Given this list of marker genes HCRTR1, MIA, FOXD3-AS1, AZGP1, PLAC9P1, GPR83, COL20A1, ST3GAL6-AS1, POLR3G, LINC02024, MPZ, GJC3, CDH19, SHC4, TFAP2A, OLFML2A, ARHGEF26, PLP1, PCDH20, MYOT, DCT, SOX2, CMTM5, NKAIN2, RBMS3-AS3, GFRA1, GRIK3, GPR12, WNT16, LINC02082, NKAIN3 (sodium/potassium transporting ATPase interacting 3), SYNPR (synaptoporin), PAQR6, FAM181B (NCBI Gene Id 283223), LGI4, ASPA, ZMYM4-AS1, CNP, ERBB3, LINC02300, RASGEF1C, FOXD3, NLGN3, GPR17, LINC01198, VSTM2B-DT, LINC01505, PMP2, TAC1, BCAN, INSC, DEPDC7, SOX2-OT, GINS3, PRIMA1, ST8SIA5, SLC16A4, ADAM23, HS3ST4 (heparan sulfate-glucosamine 3-sulfotransferase 4), TSPAN11, PAPPA-AS1, MDGA2, PTPRZ1, MEGF10, SDK2, COL28A1, CRYM, RPL13AP2, S100B, SOX10, COL25A1, PRNP, B3GALT2, LINC00648, MMD2, here is a description of the gene set: Human Gene Set: DESCARTES_FETAL_PANCREAS_ENS_GLIA Marker genes curated from the annotated cluster as represented in the Descartes Human Gene Expression During Development database. The gene expression program underlying the specification of human cell types is of fundamental interest. The study authors generated human cell atlases of gene expression and chromatin accessibility in fetal tissues. For gene expression, the study authors applied three-level combinatorial indexing to >110 samples representing 15 organs, ultimately profiling ~4 million single cells. The study authors leveraged the literature and other atlases to identify and annotate hundreds of cell types and subtypes, both within and across tissues. Our analyses focused on organ-specific specializations of broadly distributed cell types (such as blood, endothelial, and epithelial), sites of fetal erythropoiesis (which notably included the adrenal gland), and integration with mouse developmental atlases (such as conserved specification of blood cells). These data represent a rich resource for the exploration of in vivo human gene expression in diverse tissues and cell types. studied in species Homo sapiens from publication Cao J, O'Day DR, Pliner HA, Kingsley PD, Deng M, Daza RM, Zager MA, Aldinger KA, Blecher-Gonen R, Zhang F, Spielmann M, Palis J, Doherty D, Steemers FJ, Glass IA, Trapnell C, Shendure J (PMID 33184181)